Given this list of marker genes SLC25A42, ANKH, SLC25A6, SLC25A24, ABCC6, SLC25A25, CALHM6, CALHM1, CR1 (complement C3b/C4b receptor 1 (Knops blood group)), CALHM5, SLC25A5, CALHM3, SLC25A4, SLC17A9, SLC25A41, ADCY10, CD47, SLC25A31, SLC25A23, SLC35B1, PANX1, CALHM2, SLC25A17, CALHM4, here is a description of the gene set: The directed movement of ATP, adenosine triphosphate, into, out of or within a cell, or between cells, by means of some agent such as a transporter or pore. studied in species Homo sapiens Human Gene Set: GOBP_ATP_TRANSPORT